The following is a description of a gene set: Erythrocyte differentiation which occurs as part of the process of definitive hemopoiesis. studied in species Homo sapiens Human Gene Set: GOBP_DEFINITIVE_ERYTHROCYTE_DIFFERENTIATION, and this is the list of marker genes: SENP1, CDK5RAP3, TGFBR3, GATA1, ZFPM1